Given this list of marker genes Rnaset2b, Hhex, Lamc2, Tmem30a, Ear1, Tpi1, H19, Plin2, Lbp, Wfdc21, Zftraf1, Col18a1, Ctsz, Gns, Bbln, Bhlhe40, Arg2, H13, Snx10, Lrg1, Adgrg1, Hsph1, Mrps18b, Ros1, Pld3, Mt1, Rnf4, Cd14, Dusp6, Tpm4, Nnt, Glrx, Cxcl1, Hif1a, Hmgb3, Fcgr2b, Pafah1b3, Axin1, Mpeg1, Hdc, Rnf149, Cdkn1a, Elf5, Ak1, Bex4, Laptm5, Cndp2, Osbpl1a, Litaf (NCBI Gene Id 98032), Ndufaf4, Lap3, Cotl1, Il18, Pisd-ps1, Stxbp2, Chrnb1, Fv1, Bex1 (NCBI Gene Id 19716), Gch1, Ctsd, Fam117a, Bst1, Ostf1, Eif2ak4, Entpd1, Hibadh, Itga8, Ctsb, Slc34a2, Rpl36, Tsr1, Chd4, Bmp4, Tlcd4, Gja1, Acsl4, Ly6d, Rrbp1, Il13ra2, Npc2, Lrrfip1, Kdelr1, Gja3, Epha7, Ctsa (cathepsin A), Camsap1, Atp6v1c1, Pparg, Slc4a4, F3, Xbp1, Ighv1-14, Plet1, AU021092, Ly75, Tgfbi, Tes, Tob1, Scd1, Etv2, Vamp2, Clu, Crygd, Nagk, Itgb2, St6gal1, B3gat3, Ctsh, Hspa8, Nr2f1, Psmb5, Nhsl3 (NCBI Gene Id 97130), Slc31a1, Rpl28, Esrp1, Nfil3, Stard10, S100a1, Ptgs1, Thbs1 (NCBI Gene Id 21825), Iqgap1, Chl1, Scg3, Tspan8, Manf, Ccl6, AI506816, Pramel4, Pcyox1, H2-Eb1, Igha, Ighv1-54, Hoxd1, Arl8b, Vasp, Dlk1, Ehmt2 (euchromatic histone lysine N-methyltransferase 2), Trim17, Hmgn1 (NCBI Gene Id 15312), Slpi, Shmt1, Lamb3, Dap, Msr1, H2-DMb1, Adam19, Ppp2r5c, Marco, Tyrobp, Tfcp2l1, Atp1a1, Ighg2b, Il4ra, Ighv1-52, Zdhhc6, Ccnd1, Apoc1, H2-Ab1, Cldnd1, F7, Atxn10, Actn4, Gfus, Rpl10a, Vamp8, Siva1 (NCBI Gene Id 30954), Rps2, Tmem50b, Gnl3, Zdhhc3, Ctsk, Cpox, Hexa, Vegfb, St13, Man1a, Tmem268, Pkhd1, Adipor2, Pon2, Pfkl, Pcbd1, Pcyt1a, Cct3, Arglu1, Pla2g5, Slain1, Mrc1, Arg1, Fbp2, Prnp, Gstt1, Tulp2, Spg21, Nabp1, Cd68, Sirpa, Hspa1b, Klf5, Trbc1, Srsf6, Ro60, Psat1, Sdc1, St3gal4, Clic1, Reep6, Crb3, Hk2, Chil3 (chitinase-like 3), Grina, Pip4k2c, Eif3e, Ckmt1, Nme2 (NCBI Gene Id 18103), Errfi1, H2-M1, Cldn7, Psap, Eno1, Hnf1b, Gjb2, Las1l, Cyrib, Col15a1, Psca, Mdfi, Parm1, Golm1, Lgals3, Lpcat3, Cask, Lcn2, Mlec, Chchd7, Rpl8, Axl, Adcy7, Meg3, Tom1l1, Pgk1 (phosphoglycerate kinase 1), Pglyrp1, Serpine1, Ccr5 (NCBI Gene Id 235693), Matn4, Cyb5r3, Aass, Phlda2, Snd1, Epb41l4aos, Cstb, Rps8, Ldha, Gjb3, Chi3l1, Tnfsf9 (NCBI Gene Id 21950), Kras, Slc12a2, H2-Ea (NCBI Gene Id 14968), Fasn, St7, Brd7, Wls, Dsc2, Uox, Itga4, H2-DMa, H2-M9, Pdk3, Tbc1d24, Clcn5, Ank3 (NCBI Gene Id 73013), Polr1c, Gne, Atp11a, Rack1, Plp2, Nmt1, Rgcc, Btg3, Grhpr, Itgax, Socs2, Slc15a2, Krt8, Gpi1, Car8, Ptgr1, Ell2, Cnih2, Tank, Pabpc1, Atp6v0a1, Igkv10-95, Edem1, Hspa9, Muc1, Atp6v0d1, Psmd5, H2-Aa, Ighv1-59, Slc16a1, Capza3, Nup88, Id2, Galnt3, Fam3c, Mdfic, Zfp42, Pkm, Tnnt1, Anxa4, Itm2c, Hdlbp, Nudt4, Psen1, Rpl6, Polg, Gars1, Phlda1 (NCBI Gene Id 21664), Ptprf, Sec23b, Elovl1, Specc1, Mmp12, Pfdn2, 0610010K14Rik, Krt7, Nek4, Slc38a2, Hpn, Mapk1, Btg1, Cdk2ap2, Mef2b, C1qb, S100g, Avpi1, Eif1ax, Pla2g7, Plxnb2, Prxl2a, Basp1, Prelid1, Prb1c, Napsa, Igfbp3, Tm2d2, Tacstd2, Eef1d, Ctss, Cited2, Clip4, Acly, Mien1 (migration and invasion enhancer 1), Bcl2a1a, Rap1gap, Ibsp, Gapdh, Rbp4, Spint1, Eif4g1, Ifi30, Epcam (NCBI Gene Id 17075), Bsg, Mbtd1, Chia1, Cks2, Fam162a, Mt2, Plbd1, Rdh11, Psme1, Piga, Tmem62, Ctnnd2, Itih4, Aldoa, Myh7, Prcc, Mx1, Serpine2, Lrp2, Ctsc, Kcnj15, Ear2, Rida, Vil1, Cldn3, Crlf1, Ggcx, Rpl3, Polr2e, Eef2, Cd74, Zfp1, Kcnk1, Cyba (cytochrome b-245, alpha polypeptide), Mapre1, Igkv1-117, Sat1, Krt18, Aldoc, Fpr2 (formyl peptide receptor 2), Inhbb, Mia2 (MIA SH3 domain ER export factor 2), Fuca1, Atox1, Psmd4, Npdc1, Ighv1-34, Lpcat1, Pip5k1b, Azin1 (antizyme inhibitor 1), Ace2, Kng1, Rabggtb, Actn1, Csf2, Vmp1, Rpl17, Cd44, Ighg1, Cd63, Gadd45a, Hap1, Mtif2, Spp1, Soat1, Ces3b, Scamp1, Ppp1r14b, Pdia6, Hspa5, Rnf181, Eif4b, Zfp282, Ccl9 (C-C motif chemokine ligand 9), Erh, Papola, B4galnt1, Slc25a39, Tle5, Fkbp4, Marchf5, Ighv14-4, Shc1, Lilrb4b, Cd9, Atp5f1c, Fnta, Phb2, Gm33887, Csf2rb2, Cebpa, Cyb5r1, Me1, Il11, Apex1, Tnfaip1, Itpr2, Sftpb, Taok3, Csrp2, Tgoln1, Acsl5, Pgls, Orm1 (NCBI Gene Id 18405), Adss1 (adenylosuccinate synthase 1), Prdx5, Acadl, C1qc, Lcp1, Atp6v0c, Rps18, Ch25h, Nucb2, Tmem30b, Zfp143, G6pdx, Prdx4, Rfk, Hc, F10, Ceacam1, Areg, Ubqln2, Mydgf, Fkbp2, Klhdc2, Mrps34, Ncl, Ubxn1, Ccdc186, Fmr1, Cip2a, Tceal9, Rpl37, Tgif1, here is a description of the gene set: Mouse Gene Set: SWEET_LUNG_CANCER_KRAS_UP Using advanced gene targeting methods, generating mouse models of cancer that accurately reproduce the genetic alterations present in human tumors is now relatively straightforward. The challenge is to determine to what extent such models faithfully mimic human disease with respect to the underlying molecular mechanisms that accompany tumor progression. Here we describe a method for comparing mouse models of cancer with human tumors using gene-expression profiling. We applied this method to the analysis of a model of Kras2-mediated lung cancer and found a good relationship to human lung adenocarcinoma, thereby validating the model. Furthermore, we found that whereas a gene-expression signature of KRAS2 activation was not identifiable when analyzing human tumors with known KRAS2 mutation status alone, integrating mouse and human data uncovered a gene-expression signature of KRAS2 mutation in human lung cancer. We confirmed the importance of this signature by gene-expression analysis of short hairpin RNA-mediated inhibition of oncogenic Kras2. These experiments identified both a pattern of gene expression indicative of KRAS2 mutation and potential effectors of oncogenic KRAS2 activity in human cancer. This approach provides a strategy for using genomic analysis of animal models to probe human disease. Genes up-regulated in the Kras2LA mouse lung cancer model with mutated KRAS. from publication Sweet-Cordero A, Mukherjee S, Subramanian A, You H, Roix JJ, Ladd-Acosta C, Mesirov J, Golub TR, Jacks T (PMID 15608639) studied in species Mus musculus